Given this list of marker genes Kmt2b, Prmt2, Prmt5, Setd2, Ehmt1, Prdm9, Ash1l, Setd3, Ash2l, Suv39h2, Kmt2a, Smyd1, Setbp1, Kmt2e, Setd4 (NCBI Gene Id 93957), Setdb1, Wdr5, Carm1, Suv39h1, Smyd3, Ezh1, Setmar, Prdm8, Mettl23 (methyltransferase like 23), Smyd2, Nsd1, Ezh2, Setd7, Dot1l, Kmt2d, Prmt1, Nsd2, Jarid2, Setd1a, Nsd3, Setdb2, Mecom, Prmt9, Smyd5, Setd1b, Prmt6, Setd5, Prdm16, Kmt2c, Ehmt2, Ndufaf7, Prmt8, here is a description of the gene set: Catalysis of the reaction: S-adenosyl-L-methionine + a histone H3 = S-adenosyl-L-homocysteine + a methylated histone H3. Histone methylation generally occurs on either an arginine or a lysine residue. Mouse Gene Set: GOMF_HISTONE_H3_METHYLTRANSFERASE_ACTIVITY species: Mus musculus